The following is a description of a gene set: Human Gene Set: HP_EXUDATIVE_VITREORETINOPATHY Exudative vitreoretinopathy species: Homo sapiens, and this is the list of marker genes: CTNNB1, TSPAN12, ZNF408, NDP, VCAN, BAP1, LRP5, FZD4